Given this list of marker genes SLC7A11, SLC7A7, SLC36A4, SLC7A3, SLC43A1, SLC36A2, SLC38A3, SLC7A6, SLC38A5, SLC38A2, SLC1A5, SLC3A2, SLC43A2, SLC6A14, SLC6A18, SLC3A1, SLC6A15, SLC7A10, SLC38A1, SLC25A29, SLC7A1, SLC6A19, SLC6A12, SLC1A4, SLC7A2, SLC7A5, SLC6A6, SLC7A9, SLC6A20, SLC16A10, SLC38A4, SLC36A1, SLC7A8, here is a description of the gene set: studied in species Homo sapiens Amino acid transport across the plasma membrane Human Gene Set: REACTOME_AMINO_ACID_TRANSPORT_ACROSS_THE_PLASMA_MEMBRANE